The following is a description of a gene set: Any process that modulates the rate, frequency or extent of hydrogen peroxide biosynthesis. The chemical reactions and pathways resulting in the formation of hydrogen peroxide (H2O2), a potentially harmful byproduct of aerobic cellular respiration which can cause damage to DNA. Human Gene Set: GOBP_REGULATION_OF_HYDROGEN_PEROXIDE_BIOSYNTHETIC_PROCESS species: Homo sapiens, and this is the list of marker genes: ZNF205, STAT3, DUOXA1, FYN, MPV17L, DUOXA2, SOD2